Given this list of marker genes Uhrf1, Pttg1, Sgo1, Chmp1a, Knl1, Riok2 (NCBI Gene Id 73706), Smarcd2 (SWI/SNF related, matrix associated, actin dependent regulator of chromatin, subfamily d, member 2), Tex11, Snhg15, Kif2b, Ccsap, Mad1l1, Cdc6, Tex15, Sun1, Spice1, Shoc1, Syce1, Dync1li1, Ccnb1ip1, Ube2b, Ncaph, Lcmt1, Ndc80, Lsm14a, Kifc1, Top2b, Cenpq, Smarca4, Dctn2, Ripor2, Mael, Mlh3, Msh5, M1ap, Spc24, Sirt2, Aaas, Klhdc8b, Terb1, Smarcc2, Bub1b, Nup62, Ofd1, Cdk1, Clasp2, Spata22, Tubg1, Ttk, Kif2c, Rrs1, Smarcd1, Prickle1, Dpf1, Ccne1, Katnb1, Prpf4b, Golga2, Stag3, Spc25, Cdc16, Smc3, Cpeb1, Bub3, Smc4, Top2a, Ttl, Racgap1, Birc5, Rec8, Cep63, Cep192, Phf13, Dpf2, Kat5, Dync1h1, Bag6, Nsmce2, Mzt1, Cenpc1, Ncapd2, Ndc1, Ccne2, Kif18b, Terf1, Morc2b, Kat2b, Rnf212, Nek2, Plk1, Kifc5b, Brip1, Pten, Vps4a, Kif2a, Ino80, Dmc1, Tpr, Meikin, Cdt1, Map9, Chmp4c, Kif23, Tex12, Poldip2, Ddb1, Cit, Trappc12, Atf6b, Klhl22, Arhgap33os, Mapre1, 4930447C04Rik, Ncapd3, BC005624, Haspin, Ect2, Zwilch, Smarca5 (NCBI Gene Id 93762), Prdm9, Pbrm1, Hormad1, Atm, Anapc1 (NCBI Gene Id 99393), Sirt7, Fancd2, Aurkb, Septin1, Dsn1, Pcid2, Ppp2r1a, Syce3, Chmp1b, Ago4, Cdca5, Smarcd3, Cdk5rap2, Gen1, Phf10 (NCBI Gene Id 72057), Akap8l, Dis3l2, Nuf2, Map10, Kash5, Ccnb1-ps, Ska1, Mei4, Smc2 (structural maintenance of chromosomes 2), Nudc, Dcaf13, Bcl7c, Bcl7b, Chmp2a, Wrap73, Mos, Zcwpw1, Washc5, Kif3b, Espl1, Arid2, Ncaph2, Ska2, Cltc, Stag1, Psmc3ip, Mybl2 (myeloblastosis oncogene-like 2), Mre11a (MRE11A homolog A, double strand break repair nuclease), Kif22 (kinesin family member 22), Hecw2, Xrcc3, Brca2, Vps4b, Rab11a, Bcl7a, Numa1, Nsl1, Tpx2, Ncapg, Baz1b, Cul3, Knstrn, Eml3, Chmp4b, Abraxas2, Rnf212b, Arid1a, Anapc2, Psrc1, Nipbl, Cenpf, Tex14, Ncapg2, Cep97, Brd7, Ube2u, Zw10, Syce2, Terb2, Flna, Ccnb2, Dusp1, Anapc5 (NCBI Gene Id 67965), Iho1, Ska3, Pmf1, Ube2c, Gem, Smarcb1, Ankrd53, Stag2, Incenp, Hspa1a, Kpnb1, Rcc2 (regulator of chromosome condensation 2), Abraxas1, Sycp3, Apc, Ccnb1, Mapk15, Actr2, Meiob, Chmp6, Eml4, Becn1, Tubg2, Champ1, Spdl1, Chfr, Nek6, Rangrf, Cenpe, Hnrnpu, Spo11, Chek2, Chmp3, Kif14, Spag5, Aurka (aurora kinase A), Rcc1 (NCBI Gene Id 66739), Rhoa, Msh4, Bub1, Smc1a, Tex19.1, Washc1, Khdc3, Mei1, Syce1l, Smarca2, Rb1, Sirt1, Tacc3, Prc1, Chmp5, Kif11, Fbxo5, Usp44, Actl6b (actin-like 6B), Cdc27, Hspa1b (NCBI Gene Id 15511), Ran, Bend2, Aspm, Spdya, Mis12, Ccdc66, Psmg2, Meioc, Anapc15-ps, Anapc11, Actr3, Cdc23 (CDC23 cell division cycle 23), Misp, Chmp7, Cdc20, Seh1l, Zfp207, Wapl, Anapc7, 1700028K03Rik, Syde1, Mad2l1, Rad21l, Rmi2, Akap8, Pibf1 (progesterone immunomodulatory binding factor 1), Ankrd31, Dpf3, Trip13 (thyroid hormone receptor interactor 13), Sycp1, Ehmt2, Cdc42, Kif4, Cenpk, Arhgef10, Anapc15, Chmp2b, Kif18a, Drg1, Map1s, Ik, Lats1, Clasp1, Nusap1, Cenpi, Cdca8, Mcmdc2, Anapc4, Kntc1, Rad21, Majin, Kif15, Actl6a, Zwint, Fam83d (family with sequence similarity 83, member D), Mnd1, Pinx1, Mlh1, Mad2l1bp, Smarce1, Ccdc61, Prap1, Smarcc1, Actb (NCBI Gene Id 11476), Fmn2, Bccip, Chmp1b2, here is a description of the gene set: species: Mus musculus The process in which genetic material, in the form of nuclear chromosomes, is organized into specific structures and then physically separated and apportioned to two or more sets. Nuclear chromosome segregation begins with the condensation of chromosomes, includes chromosome separation, and ends when chromosomes have completed movement to the spindle poles. Mouse Gene Set: GOBP_NUCLEAR_CHROMOSOME_SEGREGATION